Given this list of marker genes PDK1, SOX2, KCNAB1, PFKL, AK4, JMJD6, TMPRSS11D, CAVIN2, FST, RPL27, PGM1 (NCBI Gene Id 5236), PGK1, RPS6KC1, ENO1, PROKR1 (NCBI Gene Id 151012), TPI1, RAMP3, FAM162A, ERO1A, LDHB, HELT, GBE1, GAPDH, BNIP3 (BCL2 interacting protein 3), LGALS3, ADM, here is a description of the gene set: Genes down-regulated in SEND cells (skin endothelium) at normal oxygen (normoxia) conditions after knockdown of HIF1A by RNAi. from publication Gross C, Dubois-Pot H, Wasylyk B (PMID 17704799) species: Mus musculus Human Gene Set: GROSS_HIF1A_TARGETS_DN The ternary complex factor Net/Elk3 is downregulated in hypoxia and participates in the induction by hypoxia of several genes, including c-fos, vascular endothelial growth factor and egr-1. However, the global role of Net in hypoxia remains to be elucidated. We have identified, in a large-scale analysis of RNA expression using microarrays, more than genes that are regulated by Net in hypoxia. In order to gain insights into the role of Net in hypoxia, we have analysed in parallel the genes regulated by HIF-1alpha, the classical factor involved in the response to hypoxia. We identified about genes that are regulated by HIF-1alpha in hypoxia. Surprisingly, when we compare the genes induced by hypoxia that require either Net or HIF-1alpha, the majority are the same (75%), suggesting that the functions of both factors are closely linked. Interestingly, in hypoxia, Net regulates the expression of several genes known to control HIF-1alpha stability, including PHD2, PHD3 and Siah2, suggesting that Net regulates the stability of HIF-1alpha. We found that inhibition of Net by RNAi leads to decreased HIF-1alpha expression at the protein level in hypoxia. These results indicate that Net participates in the transcriptional response to hypoxia by regulation of HIF-1alpha protein stability.